Given this list of marker genes ATP5MC3, NDUFA2, SLC38A5, ATP6V1G2, ATP6V1A, NDUFS7, NDUFA6, TMEM175, NDUFA8, ATP6V1H, SLC36A3, ATP6V1C1, MT-ND1, ATP5PO, COX5A, NDUFA4, NDUFV3, SLC46A1, SLC11A2, SLC2A13, MT-CYB, SLC4A11, NDUFS5, MT-ND6, SLC30A1, MT-ND3, SLC36A1 (NCBI Gene Id 91974), ATP6V0E2, COX5B, MT-ATP8, NDUFS3, SLC9A1, SLC15A1 (solute carrier family 15 member 1), NDUFV2, UQCRC1, ATP6V1F, CTNS, SLC16A1, NDUFB1, MT-ND2, ATP6V1D, OTOP1, SLC9A4, HVCN1, SLC15A2, ATP5MG, SLC36A2, MT-CO3, SLC45A1, COX7A2L, SLC17A7, GHITM, NDUFS2, STING1, NDUFB9, MT-ND5, SLC9A7, NDUFB6 (NADH:ubiquinone oxidoreductase subunit B6), SLC25A13, SLC2A10, MT-ND4, NDUFA1, MT-ATP6, SLC9C1, COX6B1, ATP6V0D1, NOX5, NDUFS1, COX4I1, ATP5F1D, OTOP2, SLC9B2, UCP1, NDUFB7, NDUFS4, ATP6V0C, SLC9A5, ATP6V0D2, ATP6V1E1, SLC9A3, UCP2, NDUFV1, ATP5PD, ATP5MC1, NDUFA3, NDUFA7, SLC16A3, ATP5MC2, ATP4A, ATP5F1A, SLC9C2, TCIRG1, NDUFS8, NDUFB3, SLC25A5, SLC9B1, ATP5MF, SLC38A3, ATP6V0A1, SLC18A1, SLC47A2, CYBB, SLC18B1, ATP4B, CHP1, SLC45A3, NDUFA12, CLCN7, NDUFB8, SLC18A2, MT-CO1, SLC32A1, MT-ND4L, COX7B, ATP12A, SLC30A6 (solute carrier family 30 member 6), ATP6V1B1, SLC47A1, SLC17A5, ATP6V1C2, SLC9A2, UQCRH, ATP6V1B2, UCP3, UQCR10 (ubiquinol-cytochrome c reductase, complex III subunit X), SLC2A9, TMCO3, SLC30A5, ATP5MGL, ATP5F1EP2, MT-CO2, COX8A, SLC9A8, CLCN3, SLC25A4, SLC25A12, ATP6V1G3, SLC9A6, ATP5F1B, UQCRFS1P1 (ubiquinol-cytochrome c reductase, Rieske iron-sulfur polypeptide 1 pseudogene 1), NDUFA5, SLC25A3, NDUFB4, LETM1, ATP5ME, SLC9A9, ATP6V1G1, NDUFB2, SLC30A2, CYC1, NNT, ATP6V0B, SLC30A8, ATP5PF, ASIC5, SLC25A14, SLC25A27, NDUFS6, NDUFC1, SLC15A3, DMAC2L, NDUFC2, SLC45A2 (NCBI Gene Id 51151), SLC25A22, ATP6V1E2, ATP5F1C, SURF1, SLC15A4, SLC25A18, NDUFB5, ATP5PB, OTOP3, SLC45A4, SLC18A3 (NCBI Gene Id 6572), NDUFB10 (NADH:ubiquinone oxidoreductase subunit B10), ATP6V0E1, ATP6V0A2, ATP5F1E, SLC11A1, MTCO2P12, NDUFA9 (NCBI Gene Id 4721), ATP6V0A4, UQCRFS1, COX7A1 (NCBI Gene Id 1346), NDUFA10, SLC17A6, here is a description of the gene set: Human Gene Set: GOMF_PROTON_TRANSMEMBRANE_TRANSPORTER_ACTIVITY Enables the transfer of a proton from one side of a membrane to the other. studied in species Homo sapiens